The following is a description of a gene set: studied in species Homo sapiens Neonatal seizure Human Gene Set: HP_NEONATAL_SEIZURE A seizure occurring within the neonatal period (28 days beyond the full term date)., and this is the list of marker genes: KCNQ2, CDKL5, MECP2, NTNG1 (NCBI Gene Id 22854), KCNQ3, SMC1A, SCN8A, GABBR2, SCN2A, EIF2AK2, PRRT2